The following is a description of a gene set: Human Gene Set: GOBP_CD4_POSITIVE_ALPHA_BETA_T_CELL_DIFFERENTIATION species: Homo sapiens The process in which a relatively unspecialized T cell acquires specialized features of a mature CD4-positive, alpha-beta T cell., and this is the list of marker genes: NFKBIZ, CBFB, HMGB1, HLA-DRB1, CD69, IL4R, ATP7A, ZFPM1, NFKBID, LGALS9, TOX, ZBTB7B, CRACR2A, BCL6, ZC3H12A (NCBI Gene Id 80149), MTOR, GPR65, CD80, SPN, RC3H1, IRF4, RUNX1 (NCBI Gene Id 861), CD83, LEF1, BRD4, RORC, STAT3, FOXP3, TMEM98, BCL3, KCNK18, ICOSLG, NCKAP1L, RSAD2, RORA, RARA, IL27, STAT6, TBK1, EP300, IL6R, ASCL2, CCL19, BRAF, IL12B, PLA2G2D, ICOS, IL6ST, NKX2-3, ANXA1, JAK3 (NCBI Gene Id 3718), PIK3R1, LY9, PRKCZ, RUNX3 (RUNX family transcription factor 3), IL23A, MIR21, BRD2, GATA3, CD86, IL18, OPA1, JUNB, SH3RF1 (NCBI Gene Id 57630, SH3 domain containing ring finger 1), ENTPD7, PTGER4, TBX21, SEMA4A, HLX, IL18R1, MYB, BATF, ARMC5, LOXL3, IL2, RC3H2, RELB, FUT7, MALT1, SMAD7, SOCS3, RIPK2, GPR183, MEN1, IL23R, TNFSF4, STAT4, NLRP3, IL2RG, FOXP1, LGALS1, SASH3, SHB, STAT5A, CTSL, SOCS1, PDP2, KMT2A, IL12RB1, SLAMF6, SOCS5, TNFSF18, JAK1, IFNG, HLA-DRA, IL21, IL6, KLHL25